The following is a description of a gene set: species: Homo sapiens Human Gene Set: GOCC_MRNA_EDITING_COMPLEX A protein complex that posttranscriptionally catalyzes insertion, deletion or substitution of nucleotides at multiple sites within nascent mRNA transcripts to produce mature mRNAs in eukaryotes., and this is the list of marker genes: APOBEC3F, APOBEC3G, HNRNPAB, SYNCRIP, APOBEC1, A1CF, RBM47